The following is a description of a gene set: Human Gene Set: GSE13485_CTRL_VS_DAY7_YF17D_VACCINE_PBMC_DN species: Homo sapiens Genes down-regulated in comparison of unstimulated peripheral blood mononuclear cells (PBMC) versus PBMC 7 days after stimulation with YF17D vaccine. The immune responses generated by YF-17D by profiling genes in 25 vaccine recipients were accessed at days 1, 3, 7, and 21 post-vaccination compared to pre-vaccination in PBMCs. The immune responses generated by YF-17D by profiling genes in 25 vaccine recipients were accessed at days 1, 3, 7, and 21 post-vaccination compared to pre-vaccination in PBMCs. from publication Querec TD, Akondy RS, Lee EK, Cao W, Nakaya HI, Teuwen D, Pirani A, Gernert K, Deng J, Marzolf B, Kennedy K, Wu H, Bennouna S, Oluoch H, Miller J, Vencio RZ, Mulligan M, Aderem A, Ahmed R, Pulendran B (PMID 19029902), and this is the list of marker genes: MKI67, CYP2J2, CNP, PIN4, PSMA4, FCGR1BP, CASP5, UBE2L6, PLXNC1, PIK3AP1 (phosphoinositide-3-kinase adaptor protein 1), TRIM5, CHMP5, IFI44, IFITM2, ANKRD22, TNFSF10, ADAR, ZCCHC2, MSR1 (macrophage scavenger receptor 1), MSH2, MYD88, IFI44L, CCR1, SASH1, STAT2, TRIP6, PSME2, CXCL11, ERICH3, GPBAR1, LGALS3BP, PI4K2B, LAP3, MT2A, AIM2, TMEM255A, AXL, OAS3, SLC12A8, ADA2, GNGT2, RNF213, EIF2AK2, TPX2, IFITM1, SMC1A, SPTLC2, FANCL, RSAD2, APOBEC3A, REC8, IRF9, SPATS2L, GBP4, LDLR, ZWINT, IRF7, CCR5, XAF1, CMTR1, SAMD4A, MRPS18C, MS4A7, KMO, ZBP1, BRCA2, GBP1, TRIM22, IFI6, CCL8, ATP13A1 (ATPase 13A1), IFI27, HERC6, KCTD14, SCO2, ANKFY1, NMI, TAP1, SHFL, GCH1, TIMELESS, LRRCC1, LGALS9, OAS2, JUP, PARP9, IL15RA, IFIT3, BST2, SIGLEC1, NCOA7, MARCKS, TRIM14, ACP2, MX2 (MX dynamin like GTPase 2), IFI16, DTX3L, APOL6, TRIM69, GBP3, LY6E, JAK2, RIGI, LILRB1, LAIR1, BLVRA, IL1RN, TCN2, IFIT2 (interferon induced protein with tetratricopeptide repeats 2), HESX1, TTC21A, HMMR, TRIM25, SP110, PARP12, RIN2, GRIN3A, OTOF, ATP10A, IFI35, RTP4, MYO10, CX3CR1, SAMD9, RTCB, IFITM3, DDX60, CYSLTR1, ADAP2, PSMB8, ISG15, UTRN, LCP2, SHISA5, SERPING1, NAGK, RBBP8, C2 (NCBI Gene Id 12263), CXCL10, BATF2, GMPR, TYMS, PRPSAP1, FMNL2, SLC31A2, VSIG10L, STAT1, IL15, CIMAP1B, TDRD7, CMPK2, IL4I1, PLAC8, CBR1, PARP10, NEXN, MVB12A, NLRP3, ACOT9, OAS1, SCARB2, MX1, TNFSF13B, DHX58, PSMB9, KLHDC7B, PARP14, TYMP, VRK2, TOR1B, IFIT5, PLSCR1, FBXO6, HEG1, RGL1, OASL, RAD51AP1, USP18, CD38, MS4A4A, LINC00487, SP100, MTHFD2, LAMP3 (NCBI Gene Id 27074), IFIH1, FOSL1, DDX60L, C3AR1, SECTM1, TCF7L2, PHF11, HERC5, MYOF (myoferlin), IFIT1, EPSTI1, SAMD9L, C1GALT1C1, PNPT1, NID1, KIAA1958